The following is a description of a gene set: Any process that modulates the frequency, rate or extent of meiotic cell cycle phase transition. studied in species Homo sapiens Human Gene Set: GOBP_REGULATION_OF_MEIOTIC_CELL_CYCLE_PHASE_TRANSITION, and this is the list of marker genes: CHFR (NCBI Gene Id 56732), CDC25A, OVOL1, ZWINT, PKMYT1, CDC25C, KNL1, USP17L2, PDIK1L, TTK, CDC25B, STK35, MOS, MAPK15